The following is a description of a gene set: Mouse Gene Set: GOBP_NEGATIVE_REGULATION_OF_SKELETAL_MUSCLE_TISSUE_DEVELOPMENT studied in species Mus musculus Any process that stops, prevents, or reduces the frequency, rate or extent of skeletal muscle tissue development., and this is the list of marker genes: Twist1, Tgfb1, Usp19, Ybx3, Usp2, Nras